The following is a description of a gene set: A developmental disorder of the lacrimal drainage system that most often affects the lacrimal ostium and resulting in non-opening of the nasolacrimal duct. It usually results from a non-canalization of the nasolacrimal duct. Lacrimal duct atresia Human Gene Set: HP_LACRIMAL_DUCT_ATRESIA species: Homo sapiens, and this is the list of marker genes: TP63, NDUFB11, SMCHD1 (NCBI Gene Id 2490), FGFR3, IGSF3, PAX3